Given this list of marker genes ZNF420, RNF6, SELENOS, GOPC, SEC63, DPY19L3, MYORG, CHCHD3 (NCBI Gene Id 54927), ANXA7, AFTPH (aftiphilin), UEVLD, ARL8A, MPEG1, FOXL1, UBE2D2, FUT9, MDGA1 (MAM domain containing glycosylphosphatidylinositol anchor 1), ANTXR1, ZNF789, KAT6A, CASKIN2, CRYZ, BACH2, TMPRSS11A, EIF4B, SLCO5A1, GNB1, TTC23L, SERPINB8, TNFSF10, TMPO (NCBI Gene Id 7112), DTNA, UBE2E2, CEP126, UBR7, PREP, MMP1, SAMD12, MED13, LHX1, A1CF, KLF7, DNAJC25, ARL15, IQCJ, DLD, HYDIN, ZNHIT6, PRKCA, PJA2, SH2D4B, ADAMTS3, ERVFRD-1, SRPRA, FRA10AC1, PURG, NCBP2, ZNF649, PLAGL2, SLC11A2, RANBP9, KANSL1, SLC41A3, PIAS3, MIB1, MAPK8IP3, NEB, EHMT1 (NCBI Gene Id 79813), SAXO1, FBXO28, RND2, DUSP28, SATB2, RMDN3, UBE2H, CHMP5, GRK2, KIF5B, MAP4K1, here is a description of the gene set: Human Gene Set: MIR12127 species: Homo sapiens Genes predicted to be targets of miRBase v22 microRNA hsa-miR-12127 in miRDB v6.0 with MirTarget v4 prediction scores > 80 (high confidence targets). from publication Chen Y, Wang X (PMID 31504780)